Given this list of marker genes Khnyn, Zfp706, Trp53inp1, Slc30a1, Sec22c, Tstd2, Mon2, Atg13, Rgp1, Grm5, Rbm15, Fgf15, Cyth3, Rfx3, Ncs1, Vezf1, Arrb1, Tnks2, B3gnt9 (UDP-GlcNAc:betaGal beta-1,3-N-acetylglucosaminyltransferase 9), Mpl (myeloproliferative leukemia virus oncogene), Pign, Chtf8, Ehd1, Ptpn2, Strip1, Kdm6b, Lrrc1, Tex9, Atxn7l3, Srrm2, Stoml1, Ncoa5, Atrnl1, Ppargc1a, Cyp17a1, Batf3, Cpeb1, Atp2a2, Bcl9, Btg1, Sostdc1, Ppp1r15b, Inpp5b, Ctif, Pdss1, Rab6b, Npas3, Slc23a2, Col9a3, Smurf1, Usp42, Lrch1, Slc18a2, Frmd8, Lipk, Jade2, Tmie, Cacna1h, Net1, Kctd10, Rhod, Baz2a, Kif2a, Rimkla, Gnai3, Clvs1, Glrb, Zbtb43, Stk39, Ywhah, Litaf, Exo1, Slc44a1, Serpina3j, Yars1 (NCBI Gene Id 547379), Mrps17, Rsbn1, Gpd1, Dab1, Grsf1, Kdm3a, St18, Lrrc73, Pramel12, here is a description of the gene set: Genes predicted to be targets of miRBase v22 microRNA mmu_miR_3966 in miRDB v6.0 with MirTarget v4 prediction scores > 80 (high confidence targets). from publication Chen Y, Wang X (PMID 31504780) Mouse Gene Set: MIR_3966 species: Mus musculus